The following is a description of a gene set: Mouse Gene Set: MIR_26A_1_3P Genes predicted to be targets of miRBase v22 microRNA mmu_miR_26a_1_3p in miRDB v6.0 with MirTarget v4 prediction scores > 80 (high confidence targets). from publication Chen Y, Wang X (PMID 31504780) studied in species Mus musculus, and this is the list of marker genes: Nus1, Nobox, Vkorc1l1, Foxo1, Atp6v1c1, Zfp281, Snx1, Ppp1r21, Zfand6, Gvin3, Bbx (bobby sox HMG box containing), Atp2b3, Hoxc8, Scarb2, Cacnb4, Glt28d2 (glycosyltransferase 28 domain containing 2), Ogt, Bche, Igf2bp3 (insulin-like growth factor 2 mRNA binding protein 3), C330018D20Rik, Cp, Efna5, Prrx1, Sel1l3, Ppp2r2b, Adi1, Ppargc1b, Dnal1, Ubtfl1, Rbm39, Tmem45a2, Lamp2 (NCBI Gene Id 16784), Gvin2, Fgf7, Tet1, Cd226, Pik3c2a, Gvin1, Zdhhc21, Krt13, Ppp2r1b, Stag1, Nphp3, Rimklb, Syncrip, Cyp2c50, Mpdz, Smarce1, Gzmb, Col10a1, Usp6nl, Cd69, Eml6